The following is a description of a gene set: Human Gene Set: AP2REP_01 studied in species Homo sapiens Genes having at least one occurrence of the motif CAGTGGG in the regions spanning 4 kb centered on their transcription starting sites. This matches the KLF12 transcription factor binding site V$AP2REP_01 (v7.4 TRANSFAC)., and this is the list of marker genes: CALM3, FXYD6, PRPH, COL16A1, HOXC6, PCSK6, ADAMTS4, PTMA, BARHL2, BRD4, TRPM3, ARID1A, SLC6A5, IGFALS, WT1-AS, TICAM1, NHLH2, ECH1, MARCKSL1, IRAG1, ACVR1, GRIN2A, GNB2, SCAMP3, YWHAG, ZIC5, RPL22, EFNB1, JPH1, GNG3, PHYHIPL, TRPV5, UBE2H, CACNB3, KMT2A, DYRK1B, BCL2L11, TMEM191A, IRX4, TNKS1BP1, MYO1C, SCAMP5, TEX2 (NCBI Gene Id 55852), EPHA1, SERPINB2, CBLL1, EYA4, GATA1, NKAIN1, FAM219A, RHOJ, MEMO1, PCBP4, SERPINF1 (serpin family F member 1), NFKBIE, MIR9-1HG, EFNA5, TACSTD2, LCAT, AMFR (NCBI Gene Id 267), PAK6, BHLHE22, MSN, ITSN2, ARHGAP6, GRIN3A, MAPT, SAXO4, FRMPD1, RHOG, FANCI, TSC22D1, RTF1, PDZRN4, ADNP, KLK13, TSHZ2, WNT4, IER5L, LTBP3, CLPTM1, ZBTB4, CD3G, COBL, BCL9L, MORF4L2, DNAI1, SHANK2, RBM14, TNPO1, PDE10A, C1orf43, CHRM1, HMCN1, NR3C2, RORA, DNMT3A, NXPH1, WDPCP, ANKRD39, TXLNG (NCBI Gene Id 55787), JMJD1C, PHC2, VIM, TUBB2B, MPO, GMPPB, ATP2B2, RAP2C, AMER1, IRAK1, NEFL, POC1A, CD3D, ATN1, POLR2A, KRT72, TFIP11, PANK1, NLGN3, PARD6A, NOSTRIN, DDIT4L, MYOZ1, RUNX1T1, UBE2E2, MRI1, CYB561D1, SH3D21, PTGDS, EBF2, BMP1, IL3, CCN1, MAST4, WDTC1, RRP36, JPH2, SMARCA5, CCDC177, U2AF1L4, NUDT11, BSCL2, NUDT10, YBX2, TBC1D10A, ZDHHC15, FHIT, BEND6, PPOX, ATL2, PUM1, SMURF2, EED, CPLX2, CALD1, TMEM35A, DNHD1, EIF5A (NCBI Gene Id 1984), ZHX2, KRT35, CYP8B1, CA7, PIK3R3, KRT17, ATP5PD, BTBD9, ARHGAP44, TNPO2, DAAM1, CHMP2B, PHF12, FAM180A, NKX3-1, NRG1, CPNE1, AKIRIN1, PDYN, NT5DC2, TMEM185A, PBX1, IKZF4